The following is a description of a gene set: Human Gene Set: FAN_EMBRYONIC_CTX_MICROGLIA_1 from publication Fan X, Dong J, Zhong S, Wei Y, Wu Q, Yan L, Yong J, Sun L, Wang X, Zhao Y, Wang W, Yan J, Wang X, Qiao J, Tang F (PMID 29867213) species: Homo sapiens, and this is the list of marker genes: SPAG5, ANLN, CEP55, GGH, CNTRL, RHEB, NDC80, EZH2, ATAD2, PRR11, TCF19, KIF20B, H2AZ2, POLQ, TUBB4B, NCAPH, MRPL18, KIF14, ARHGAP11A, NUF2, MND1, DDX39A, ATAD5, BIRC5, BUB1B, TMEM106C, MXD3 (NCBI Gene Id 83463), KIF11, CCNB1, TMPO, BUB3, ITGB3BP, BRCA2, KIF2C, TACC3, CKS2, SMC2, MKI67, HP1BP3, NCAPG, H2AZ1, KIF20A, TK1, GTSE1 (G2 and S-phase expressed 1), CDCA3, ENSG00000187951, IQGAP3, KPNA2, CDKN3, HMGB2, H2AX, PCNA, SIVA1, RAD51AP1, CDCA8, CENPC, NCAPG2, CIT, CENPN, CEP152, TOP2A, PHF19, ASPM, CKAP2 (cytoskeleton associated protein 2), KNL1, FOXM1, CCNA2, DTYMK, CENPW, SRSF10 (NCBI Gene Id 89048), NUSAP1, PLK4, TROAP, SPC25, FAM83D, ASF1B, TTK, BUB1, HJURP, RRM2, KIF15, H2AC17, UBE2C, RPS27L, TPX2, DEPDC1, NUCKS1, H4C3, FANCD2, CENPU, SGO2, CDC27, FBXO5, NCAPD2, ANP32E, TTF2, KNSTRN, DEK, AURKA, CCDC18, SRSF3, RAD21, CDKN2C, SGO1, CENPM, H1-3, FAM111A, CLSPN, GLA, SMC1A, CKS1B, EVI2B (ecotropic viral integration site 2B), ESPL1, CDC25C, BARD1, C21orf58, MELK, CDK1, DEPDC1B (NCBI Gene Id 94594), CCNF, MZT1, UBE2T, AURKB, CKAP2L (cytoskeleton associated protein 2 like), CDK2AP2, KIF23, PIMREG, CENPF, NRM, KIF18B, PBK, PRC1, HMMR, CKLF, CENPE, SHCBP1, MAD2L1, TUBA1C, CCNB2, DIAPH3, CDC20, SMC4, HERC5, CKAP5, PCLAF, ESCO2, ZWINT, KIF22, PLK1, ANAPC11, PTTG1, CDCA2 (cell division cycle associated 2), KIF4A, DLGAP5, ARL6IP1